Given this list of marker genes TLR3, UNC93B1, here is a description of the gene set: Reactome Pathway: UNC93B1 deficiency - HSE part of: Diseases associated with the TLR signaling cascade UNC93B1 is an endoplasmic reticulum protein with 12 membrane-spanning domains. Signaling cascades of nucleotide-sensing endosomal toll like receptors (TLR3 and TLR7-9) depends on functional UNC93B1, which is thought to deliver these TLRs from the ER to the endosome where they recognize specific pathogenic patterns and initiate host immune responses.<p>UNC93B deficiency has been implicated in the increased susceptibility to herpes simplex virus type 1 (HSV1) encephalitis (HSE), a rare complication during HSV-1 infection of the central nervous system (CNS) (Casrouge A et al. 2006). Patients-derived UNC96B1-deficient fibroblasts showed an impaired production of IFN-beta and -gamma following stimulation with TLR3 agonist poly(I:C) (Casrouge A et al. 2006). These cells were also more susceptible to HSV1 infection, showing rapid viral replication together with high mortality rates. Furthermore, pluripotent stem cells (iPSC) derived from HSE patient dermal fibroblasts were differentiated into populations of neural stem cells (NSC), neurons, astrocytes and oligodendrocytes (Lafaille FG et al. 2012). The impaired induction of IFN beta and gamma was observed in all tested CNS cells upon stimulation with poly(I:C). However, HSV1 infection selectively affected type I and III IFN production in UNC93B1-deficient neurons and oligodendrocytes (Lafaille FG et al. 2012). Thus, impaired TLR3-mediated UNC93B-dependent type I and III IFN production in respose to HSV1 infection in CNS, in neurons and oligodendrocytes in particular, may underline the pathogenesis of HSE in patients with UNC93B1 deficiency (Casrouge A et al. 2006; Lafaille FG et al. 2012).<p>Defective UNC93B1 also impairs the TLR7, TLR8 and TLR9 signaling pathways. Peripheral blood mononuclear cells (PBMCs) from UNC93B-deficient patients did not respond to the stimulation of TLR7, TLR8, or TLR9, in terms of the production of type I and III interferons, and other cytokines tested (Casrouge A et al. 2006). Moreover, no inducible CD62L shedding on granulocytes was detected after stimulation of whole blood cells derived from UNC93B-deficients patients with R-848 (agonist of TLR7 and TLR8) (von Bernuth H. et al. 2008). However, no clinical condition has been so far associated with impaired TLR7, TLR8, TLR9 due to UNC93B1 deficiency so this defect is not annotated here. species: Homo sapiens